The following is a description of a gene set: studied in species Mus musculus Mouse Gene Set: GOBP_PYROPTOTIC_INFLAMMATORY_RESPONSE A gasdermin-dependent inflammatory response that is associated with the generation of pyrogenic mediators such as IL-1beta and IL-18. Gasdermins are activated by caspase-1 or caspase-4/11, or by certain granzymes. In some, but not all cells, it can lead to pyroptotic programmed cell death., and this is the list of marker genes: Zbp1, Nlrp1b, Zeb2, Ninj1, Gzma, Gsdme, Naip2, Casp1, Aim2, Casp3, Gzmb, Gsdmc4, Gsdmc, Gbp3, Naip5, Pycard, Gsdma3, Nlrp3, Gsdmd, Gzmc (NCBI Gene Id 14940), Zdhhc5, Gsdma, Casp8, Gsdmc3, Gbp2, Gm12250, Nlrp6 (NCBI Gene Id 101613), Casp6, Naip1, Apip, Gbp2b, Dpp9, Nlrp9b, Casp4, Trim21, Gbp5, Dhx9, Trem2, Mefv, Zdhhc9, Gsdma2, Nlrp1a, Naip6, Map3k20, Gzmn, Gsdmc2, Nlrc4